The following is a description of a gene set: Covalent attachment of the ubiquitin-like protein UFM1 to a protein, forming an UFM1 chain. studied in species Homo sapiens Human Gene Set: GOBP_PROTEIN_POLYUFMYLATION, and this is the list of marker genes: UFL1, UFM1, DDRGK1, UBA5, UFC1